Given this list of marker genes CAMK2D, CAMK2G, CAMK2B, RANGRF, CACNB1, SCN3A, FGF14, SCN9A (NCBI Gene Id 93955), SCN1A, CACNG6, SCN1B, SCN5A, SCN10A, CACNA2D2, FGF11, CACNG8, FGF12, SCN8A, CACNG7, CACNG4, CAMK2A, FGF13, SCN11A, CACNB2, SCN2A, SCN2B, CALM1, CACNA1C, SCN3B, SCN4B, SCN7A, SCN4A, here is a description of the gene set: Human Gene Set: REACTOME_PHASE_0_RAPID_DEPOLARISATION Phase 0 - rapid depolarisation studied in species Homo sapiens